Given this list of marker genes RORB, SEMA4D, BAMBI, MIR100, IGFBP5, CHRD, TWIST1, IPO7, RANBP3L, MIR208A, TNF, RIOX1, UCMA, PTEN, HDAC7, ERFE, MIR320A, SUFU, SMAD3, SOX9, TMEM64, MIR93, PTCH1, GREM1, TRPM4, HOXA2, AREG, CDK6, NOTCH1, ID2, NOCT, NBR1, MIR30B, OSTN, MIR205, CRIM1, NOG, TWIST2, ID3, MIR106A, MIR18A, MIR98, FGF23, VEGFC, MIR24-1 (NCBI Gene Id 407012), AXIN2, MIR203A, TNFAIP6 (TNF alpha induced protein 6), GSK3B, PPARG, MEN1, CITED1, TMEM53, LIMD1, MIR138-1, TOB1, SFRP1, MIR214, ID1, MIR9-1 (NCBI Gene Id 407046), MIR675, HAND2, MIR17, LRP5, MIR140, SMAD6, SKI, TWSG1 (twisted gastrulation BMP signaling modulator 1), MIR125B1, here is a description of the gene set: Any process that stops, prevents, or reduces the frequency, rate or extent of osteoblast differentiation. Human Gene Set: GOBP_NEGATIVE_REGULATION_OF_OSTEOBLAST_DIFFERENTIATION species: Homo sapiens